Given this list of marker genes CEBPB, GLI1, PCNA, TNF, PTCH1, FLT3, GUCD1, AURKA, SRSF1, IL6, SRSF5, UCP2, SLC7A5, IHH, VTN, IL10, PRMT5, CSNK2A2, EZH2, CPT1A, TGFB1, RPS15, SULF2, RAP1A, CLDN1, PNPT1, CCND1, here is a description of the gene set: species: Homo sapiens The regrowth of lost or destroyed liver. Human Gene Set: GOBP_LIVER_REGENERATION